The following is a description of a gene set: NICD1 produced by activation of NOTCH1 in response to Delta and Jagged ligands (DLL/JAG) presented in trans, traffics to the nucleus where it acts as a transcription regulator. In the nucleus, NICD1 displaces the NCOR corepressor complex from RBPJ (CSL). When bound to the co-repressor complex that includes NCOR proteins (NCOR1 and NCOR2) and HDAC histone deacetylases, RBPJ (CSL) represses transcription of NOTCH target genes. Once the co-repressor complex is displaced, NICD1 recruits MAML (mastermind-like) to RBPJ, while MAML recruits histone acetyltransferases EP300 (p300) and PCAF, resulting in formation of the NOTCH coactivator complex that activates transcription from NOTCH regulatory elements. The minimal functional NOTCH coactivator complex that activates transcription from NOTCH regulatory elements is a heterotrimer composed of NICD, MAML and RBPJ. <br><br> <br>NOTCH1 coactivator complex is known to activate transcription of HES1, HES5, HEY genes and MYC and likely regulates transcription of many other genes. NOTCH1 coactivator complex on any specific regulatory element may involve additional transcriptional regulatory proteins. HES1 binds TLE proteins, forming an evolutionarily conserved transcriptional corepressor involved in regulation of neurogenesis, segmentation and sex determination. <br><br>After NOTCH1 coactivator complex is assembled on a NOTCH-responsive promoter, MAML (mastermind-like) recruits CDK8 in complex with cyclin C, triggering phosphorylation of conserved serine residues in TAD and PEST domains of NICD1 by CDK8. Phosphorylated NICD1 is recognized by the E3 ubiquitin ligase FBXW7 which ubiquitinates NICD1, leading to degradation of NICD1 and downregulation of NOTCH1 signaling. FBXW7-mediated ubiquitination and degradation of NOTCH1 depend on C-terminally located PEST domain sequences in NOTCH1. The PEST domain of NOTCH1 and the substrate binding WD40 domain of FBXW7 are frequent targets of mutations in T-cell acute lymphoblastic leukemia - T-ALL. <br><br> NICD1, which normally has a short half-life, can be stabilized by binding to the hypoxia-inducable factor 1-alpha (HIF1A) which accumulates in the nucleus when oxygen levels are low. This results in HIF1A-induced inhibition of cellular differentiation that is NOTCH-dependent. species: Homo sapiens Reactome Pathway: NOTCH1 Intracellular Domain Regulates Transcription part of: Signaling by NOTCH1, and this is the list of marker genes: TLE3, NOTCH1, NCOR1, HEYL, HDAC6, KAT2B, RBX1, CCNC, HEY2, SKP1, EP300, NBEA, TLE4, HDAC1 (NCBI Gene Id 3065), HES5, CDK8, HDAC10, TBL1X, HES1, HIF1A, MYC, UBB, HDAC11, SNW1, HDAC3, MAML2, HDAC2, HEY1, CREBBP, FBXW7, RPS27A (NCBI Gene Id 6233), TLE2, UBC, MAML1, HDAC4, TLE1, MAMLD1, CUL1, NCOR2, RBPJ, MAML3, TBL1XR1, HDAC5, HDAC8, HDAC9, KAT2A, UBA52, HDAC7